The following is a description of a gene set: Glycine degradation Human Gene Set: REACTOME_GLYCINE_DEGRADATION species: Homo sapiens, and this is the list of marker genes: KGD4, OGDH, AMT, DLST, DLD, GLDC, GCSH (NCBI Gene Id 2653)